The following is a description of a gene set: studied in species Homo sapiens PKMTs methylate histone lysines Human Gene Set: REACTOME_PKMTS_METHYLATE_HISTONE_LYSINES, and this is the list of marker genes: KMT5A, KMT5B, H4C8, SETD6, SMYD2, SUV39H1, AEBP2, H3C12, SETD1B, H3C7, KMT2C, H4C12, SETD2, H4C1, KMT2D, H4C13, SUZ12, EED, KMT2B, WDR5, H3C10 (H3 clustered histone 10), H4C14, ASH1L, SETD7, H4C15, RBBP4, SMYD3, RBBP5, MECOM, ASH2L, PRDM16, DPY30, H4C4, H3C6, DOT1L, SETD3, NSD3, EHMT2, H4C3, SUV39H2, H3C8, H4C2, RELA, H4C6, EZH2, H4C11, NSD1, H4C16, H3C2, NSD2, H3C4, H3C1, H3C11, KMT2A (lysine methyltransferase 2A), PRDM9, H3C14, SETDB2, H3C15, RBBP7, H4C9 (NCBI Gene Id 8294), SETDB1, NFKB2 (NCBI Gene Id 4791), H4C5, ATF7IP, SETD1A, H3C13, EHMT1, H3C3, NFKB1, KMT5C